Given this list of marker genes EYA1, HOXA1, ZIC3, FGFR1, MAPK3, MAPK1, PRKRA, TBX1, TWIST1, here is a description of the gene set: studied in species Homo sapiens The process in which the anatomical structures of the outer ear are generated and organized. The outer ear is the part of the ear external to the tympanum (eardrum). It consists of a tube (the external auditory meatus) that directs sound waves on to the tympanum, and may also include the external pinna, which extends beyond the skull. Human Gene Set: GOBP_OUTER_EAR_MORPHOGENESIS